The following is a description of a gene set: species: Mus musculus Any process that activates or increases the frequency, rate or extent of p38MAPK cascade. Mouse Gene Set: GOBP_POSITIVE_REGULATION_OF_P38MAPK_CASCADE, and this is the list of marker genes: Hand2, Sash1, Spi1, Zc3h12a, Il1b (NCBI Gene Id 16176), Gadd45a, Map3k3, Map3k5, Dsc2, Oprk1, Rell2, Rell1, Bmp2, Mink1, Vegfa, Met, Kcnn4, Gsn, Ager, Gadd45b, Ccr2, Bmp4, Pja2, Map3k4, Sphk1, Stk39, Lep, Gdf6, Gadd45g, Mfhas1, Xdh (NCBI Gene Id 22436)